Given this list of marker genes SLC22A9, SLCO3A1, SLCO1B3-SLCO1B7, SLC22A11, SLCO1B1 (NCBI Gene Id 10599), SLCO1B3, SLCO1A2, SLCO2B1, SLC22A6, SLCO6A1, SLCO2A1, SLC22A7, SLCO1B7, SLCO4C1, SLCO1C1, SLCO5A1, SLCO4A1, here is a description of the gene set: Human Gene Set: GOMF_SODIUM_INDEPENDENT_ORGANIC_ANION_TRANSMEMBRANE_TRANSPORTER_ACTIVITY Enables the transfer of organic anions from one side of a membrane to the other, in a sodium independent manner. species: Homo sapiens